The following is a description of a gene set: studied in species Mus musculus Reactome Pathway: Sema4D induced cell migration and growth-cone collapse part of: Sema4D in semaphorin signaling electronically inferred by orthology from the curated human pathway This event has been computationally inferred from an event that has been demonstrated in another species.<p>The inference is based on the homology mapping from PANTHER. Briefly, reactions for which all involved PhysicalEntities (in input, output and catalyst) have a mapped orthologue/paralogue (for complexes at least 75% of components must have a mapping) are inferred to the other species., and this is the list of marker genes: Erbb2, Sema4d, Rnd1, Arhgef12, Rhob